Given this list of marker genes MT-ATP8, TYROBP, TRBV3-1, S100B, TRBV19, RPS4Y1, here is a description of the gene set: studied in species Homo sapiens Thirty-eight PBMC samples from 25 patients with IPF and 13 matched controls yielded 149,564 cells that segregated into 23 subpopulations. Classical monocytes were increased in progressive and stable IPF compared to controls (32.1%, 25.2%, 17.9%, respectively, p<0.05). Total lymphocytes were decreased in IPF vs controls, and in progressive vs stable IPF (52.6% vs 62.6%, p=0.035). Tregs were increased in progressive vs stable IPF (1.8% vs 1.1% of all PBMC, p=0.007), although not different than controls, and may be associated with decreased survival (P=0.009 in Kaplan-Meier analysis; P=0.069 after adjusting for age, sex, and baseline FVC). Flow cytometry analysis confirmed this finding in an independent cohort of IPF patients. Fraction of Tregs out of all T cells was also increased in two cohorts of lung scRNA-seq. CCL22 and CCL18, ligands for CCR4 and CCR8 Treg chemotaxis receptors, were increased in IPF. The single-cell atlas of the peripheral immune system in IPF, reveals an outcome-predictive increase in classical monocytes and Tregs, as well as evidence for a lung-blood immune recruitment axis involving CCL7 (for classical monocytes) and CCL18/CCL22 (for Tregs). (From Abstract) Human Gene Set: UNTERMAN_IPF_VS_CTRL_CD8T_UP from publication Unterman A, Zhao AY, Neumark N, Schupp JC, Ahangari F, Cosme C Jr, Sharma P, Flint J, Stein Y, Ryu C, Ishikawa G, Sumida TS, Gomez JL, Herazo-Maya JD, Dela Cruz CS, Herzog EL, Kaminski N (PMID 38717443) Genes upregulated in C84 T-cells from Idiopathic Pulmonary Fibrosis Patients vs. Controls